The following is a description of a gene set: Human Gene Set: GOBP_REGULATION_OF_INNATE_IMMUNE_RESPONSE Any process that modulates the frequency, rate or extent of the innate immune response, the organism's first line of defense against infection. studied in species Homo sapiens, and this is the list of marker genes: TRIM62, S100A14, HLA-G, BPIFB1, NMI, SMIM30, TNIP2, CNOT7 (CCR4-NOT transcription complex subunit 7), MIR708, VAV1 (NCBI Gene Id 7409), TNIP1, IKBKE, FCN3, TRIM21, TKFC, FAM3A, INAVA, IL12B, GDI1, NFKBIA, NCF1, ERBIN, TMEM126A, YTHDF3, DCST1, SERPINB9, LYPLAL1, NONO, TICAM2, MIR520E, CALHM6, MIR520B, PPP2CA, PPT1 (palmitoyl-protein thioesterase 1), IL18RAP, BRCC3, NR1H3, NLRP2B, APPL1, HCK, DNAJA3 (DnaJ heat shock protein family (Hsp40) member A3), NLRC4, BIRC2, TXK, FCRL3, NFE2L2, RAET1G, FCGR2B, CSNK1A1, SUSD4, LRRC14, MAP2K6, CD226, PCBP2, HSPD1, RBM47, PAK3, TLR5, TAX1BP1, LGALS9, FADD, ZCCHC3, LAG3, RPS6KA3, UFD1, PTPN2, ZNRF1, ZNRF4, NLRC3, POLR3D, STING1, CLEC12B, ISG15, CLEC7A, NLRC5, PSPC1, ADAR, KAT5, TOMM70, COLEC11, PTPRS, P2RX7, TRIM15, ELP6, CD14, PYHIN1, ZDHHC3, TRIM5, PIK3R1, SLAMF6, SMPDL3B, ZDHHC12, CPTP, F2RL1, SH2D1B, MAPK8, HSP90B1, PLCG2, XIAP, PRKDC, GPS2, MYD88, CLNK, TRAF3, MIR20A, POLR3B, LRRC19, SLC15A4, CD160 (NCBI Gene Id 11126), PARP1, CCDC134, TRIM56, ADAM8, GPATCH3, MICA, LILRB1, UNC93B1, SRC, RASGRP4, MAPKAPK2, A2M, RELA, LILRA4, MMP12, HLA-B, INPP5D, TRIM25, USP50, RIGI, TRAF6, ZDHHC18, IRF5, TRAF3IP3, CHUK, CLEC4E, OGT, N4BP1, CDC37, POLR3F, TASL, PLA2G5, FBXL2, KCNK6, SCIMP, NOP53, NEK7, RASGRP1, STAT5A, NLRX1, GFI1, IRAK2, SARM1, NR1D1, DTX4, NFKBIZ, NFKBIL1, RAET1E, TRAFD1, TRIL, SFPQ, TYRO3, DDX41, CPT1A, MAVS, ATAT1, TRIM32, CEP63 (centrosomal protein 63), MED1, CD1D, PDPK1, TRIM41, ECSIT, VSIG4, FFAR2, EPG5, FCN1, IL12A, PPARG, COLEC10, NAGK (N-acetylglucosamine kinase), DAB2IP, TLR4, NOD2, WNT5A, PELI1, HPX, IRF4, PHB1, IFI16, HLA-F, HSP90AA1, RBM14, PYDC1, TRIM65, ZDHHC4, CD96, CYLD, LACC1, TARBP2, HSPA8, CASP1, UBE2K, IPO5, ZC3HAV1, CASP6, USP29, PJA2, RAB11FIP2, REG3G, NLRP1, GRAMD4, XRCC5, SQSTM1, IRAK1, PAK1, ITCH, GBP2 (guanylate binding protein 2), ZDHHC9, RNF125, MAPKAPK3, PARP14, CAV1, COLEC12, TNIP3, ANKRD17 (ankyrin repeat domain 17), SLAMF8, DDX60, USP15, GBP5, AKT1, RFTN1, C1QBP, CADM1, ZNFX1, LTF, RSAD2, LAMP1, BIRC3, PHB2, MIR200B, MARCHF5, PRKD1, ARG1, DHX33, MATR3, SAMHD1, IRAK3, KLRB1, METTL3, RNF144A, MFHAS1, OTOP1, NCR1, HMGB1, LILRA2, NAIP, GPR108, NLRP6, PTPN22, PLSCR1 (NCBI Gene Id 5359), FLOT2, LYAR, OAS1, FPR2, IL21, CARD9, CGAS, DRD2, MIR181B1, TNFAIP3, IFNB1, LETMD1, OASL, PARP9, PUM1, GIGYF2, MUL1, NAGLU, SPI1, UBQLN1, USP17L2, BCL10, RIOK3, ERAP1, RNF135, CRTAM, MARK4, LBP, APPL2 (NCBI Gene Id 55198), NOD1, AP1G1, TLR7, S100A8, CASP8, MIR149, TREX1, LRP8, RIPK2, FLOT1, SFN (NCBI Gene Id 2810), PAK2 (p21 (RAC1) activated kinase 2), IRGM, PRKCE, TLR8, PTPN6, SIN3A, NR1H2, MEFV, POLR3C (RNA polymerase III subunit C), RPS19, ACOD1, KIR2DS2 (NCBI Gene Id 3807), DDX39A, NINJ1, TLR1, ATG5, TRIM11, TIFA, HLA-A, ZDHHC5, TIFAB, PUM2, RNF34, TGFB1, PIM1, ALPK1, STMP1, DHX9, TRIM31, CD36, YWHAZ, MIR210, SIRT2, NLRP3, FOSL1, PIK3R6, TREM2, CD300C, ZBP1, NECTIN4, KCNJ8, DUSP10, MIR19A, OAS3, TIRAP (TIR domain containing adaptor protein), CR1, IKBKB, HCFC2, KLRC2, SLC15A3, TTLL12, KLRK1, EIF2AK2, TBK1, CACTIN, KLRC3, TYROBP, CD274, PQBP1, CREBBP, HAVCR2, MIR140, USP27X, NR1H4, KIR2DL4, WDFY1, AIM2, LEP, USP38, S100A9, TICAM1, STAT2, ABHD8, MIR17, SH2D1A, STAT5B, NLRP10, CFH, KLRC4-KLRK1, LRCH4, PIK3AP1, PTPN11, LATS1, KLRC4, EIF4E2, CD300LF, MIR146A, CLPB (ClpB family mitochondrial disaggregase), FGR, PTPN1, ZDHHC1, ESR1, BANF1, LY96, LAMP2, TSPAN6, HLA-E, BECN1, SLC15A2, LGR4, ARRB2, CD300A, SPSB3, MIR4691, KCNK13, GRB2, RNF115, SERPINB4, TLR2, HDAC6, MBL2, TIGIT, CCL5, IRF7, SCARA3, TLR9, CYBA, DHX58, TLR6, CRK, ABHD17A, TAB1 (TGF-beta activated kinase 1 (MAP3K7) binding protein 1), IRF3, PPP6C, MIR21, KLRC1, SMPDL3A, INS, APOE, EREG, RNF185 (ring finger protein 185, NCBI Gene Id 91445), POLR3G, RTN4, WASHC4, IRF1, HSPA1A, KLRD1, NPLOC4, RNF39, TNF, LSM14A, MNDA, IFI35, CD300H, ATG12, FYN, TLR3, SLC19A1, LYN, RNF170, HSPA1B, USP18, MAP3K7, NCR3, YTHDF2, SLC46A2, CARD8 (caspase recruitment domain family member 8), EP300, IFIH1 (interferon induced with helicase C domain 1), TLR10, GRN, IFNK (NCBI Gene Id 95265), RAB7B, NLRP4, PVR, SEC14L1, TREML4, OTULIN, HMGB2, CEACAM1, AARS2, YWHAE, FCN2, BTK, HEXIM1, AKIRIN2, SERPING1, SYK, LATS2, TRIM6, GKN2, NECTIN2, AP3B1, IRAK4, AURKB, DDX3X, CTSS, XRCC6, OTUD4, PYCARD, CD300E, CLEC6A, MIR200C, PYDC2, APP, PYDC5, TRIM3